The following is a description of a gene set: Genes up-regulated in skin after injection of Trypanosoma cruzi (strain Y): wildtype (BALB/c) versus IFNAR1 knockout. To investigate the early host response triggered by three different strains of Trypanosoma cruzi at a local infection site, changes in host gene expression were monitored in a murine intradermal infection model using Affymetrix oligonucleotide arrays. Robust induction of IFN-stimulated genes (ISGs) was observed in excised skin 24 hours post-infection where the level of ISG induction was parasite strain-dependent with the least virulent strain triggering a muted IFN response. Infection of mice immunodepleted of IFNγ-producing cells or infection of IFNγ-deficient mice had minimal impact on the IFN response generated in T. cruzi infected mice. In contrast, infection of mice lacking the type I IFN receptor demonstrated that type I IFNs are largely responsible for the IFN response generated at the site of infection. These data highlight type I IFNs as important components of the innate immune response to T. cruzi the site of inoculation and their role in shaping the early transcriptional response to this pathogen. We used microarrays to detail the local host transcriptional response to intradermal T. cruzi infection in WT mice and mice depleted of NK cells, or deficient in IFN-gamma or type I IFN responses. Additionally we compared the local host-transcriptional response generated to infection with 3 different strains of Trypanosoma cruzi (Y, Brazil, and G). Human Gene Set: GSE13522_WT_VS_IFNAR_KO_SKING_T_CRUZI_Y_STRAIN_INF_UP species: Homo sapiens from publication Chessler AD, Unnikrishnan M, Bei AK, Daily JP, Burleigh BA (PMID 19201883), and this is the list of marker genes: ELK3, MYO3B, PRKCA, SEPTIN8, PENK, C9orf152 (chromosome 9 open reading frame 152), STX11, ADCY9 (adenylate cyclase 9), P2RX7, ENDOD1, ANXA4, OSGIN1, WLS, CPD, PARP9, CISH (NCBI Gene Id 29917), IRGM, XXYLT1, PLXDC2, SULF2, AHNAK, PLAC8, TMEM158, RPL24, XIST, CASP7, C3orf80, TGFB3, PRG4 (proteoglycan 4), SLAMF1, TMPRSS13, PRNP, ITGAE, CORO2A, MXD1, HMGN3, LAG3, ATOSB, PHETA2, DUSP14, TSPAN13, CNGA4, IFT80, CRMP1, GPR15, OSBPL3, FAM89A, VDR, ARHGAP17, IL1R2, GFI1, NPDC1, BCL2A1, RRM2, CYTH3, KLF10, LRIG1, CTSE, CPE (NCBI Gene Id 1363), HOPX, TOX, TRIB1, RSAD2, ANGPTL2, PELI2, BIRC3, HIVEP3, GALM, DENND5A, MDFIC, TBC1D4, NFIL3, TBC1D14, SWAP70, NCOA7, GPR160, SLC35G1, YBX3, SLC22A5 (NCBI Gene Id 6584), LYSMD2, ZNF827, ABHD17C, TEX14, CD200, DUSP6, DTL, IKZF3, IL17A, GRHL1, MYO6, NCF1, PTPRS, TRPM1, TACC3, SAMHD1, SLC22A2, NCOA3, PTGER2, IKZF4, YPEL2, FAM20A, BHLHE40, C1QTNF12, NFKBIZ, DNAH7, DNMT3A, CD81, ARHGAP20, MX2 (NCBI Gene Id 4600), IL2RA, ANG, CTLA4, LTA, IFI27L2, MAP6, GLIPR2, FZD6, CCR6, PRR5L, SNX18, TRIM25, ICOS, DRC1, TNFRSF4, LETM2, EMP1, ETFBKMT, IRF4, PDCD1LG2, KCNK5, TIAM1, RGS10, RORC, MCL1 (NCBI Gene Id 4170), PRELID2, RGS1, TIMP2, SPTAN1, H2AZ1, SOCS2, BCL2L11, AQP3, PMEPA1, NTN4, ST3GAL2, CAPG, CCL20, PRKCH, MTMR3, PTPRU, WDPCP, SPRY1, CCR4, PKP4, KNTC1, IKZF2, CMPK2, GSTO1, SGO2 (NCBI Gene Id 151246), ANXA2, RNASE4, ENPP1, DPYSL2, SV2C, PUDP, PLAGL2, ISG20, NLRP12, CAPN3, ITIH5, MFSD4A (NCBI Gene Id 148808), TNFRSF9, GFOD1, CDC45, FOXP3, CUX1, FFAR4, TNFRSF18, CD86, CD79B, IGF2R, DUSP4, IL10, MYO1E, NOTCH2, TSNAXIP1, GBP4, RNF144A, DNA2, IL2RB, SLC19A2, AHCYL2, FABP5, SLC16A6, PTGIR, ADAM19, ATP6V0A1, NIBAN1, CHSY1, TRAF1